Given this list of marker genes IFIH1, DUSP16, GBP7, VOPP1, ATP8B2, NBDY, IST1, FRMD4A, SGK3, COX15, KRTAP21-1, SDC4, PRKD3, AKT2, KEAP1, HMBOX1, KLRD1, CGAS (cyclic GMP-AMP synthase), TMPO, RPS11, RIPK2, STING1, MGAT4A, ANXA1, ITGA4, C8orf33, CLASP2, N4BP1 (NEDD4 binding protein 1), SREBF2, PROS1, IGF2R, STYX (NCBI Gene Id 730432), ANKIB1, GOLGA3, C6orf15, CCDC86, RPL34, ZC3H7A, PPP2R2A, LHX2, HOXD4, SH2D4A, MARF1, PPM1K, ZNF263, CD40, KATNA1, FUNDC1, EDNRB, RCAN1, CTXN3, DENND6B, SAP30, FANCC, SLC4A7, SETDB2, KCNN4, NUP153, AFF1, LUC7L3, ARHGAP26, FNDC3B, PEX5, CD83, NONO, NIBAN1, PDGFC, TSTD1, ANXA7, GCHFR, RAMP1, PGGT1B, MTMR7, CXCL11 (NCBI Gene Id 6373), BCAS3, WDR43, GPR84, F3, SLC39A14, SPSB1, H2AZ1, YWHAZ, IGFBP4, NSRP1, FYN, MAP2K4, BATF2 (NCBI Gene Id 116071), ALDH1L1, OAS2, RPL37A, TTYH1, ZYX, GLS, MAN2A1, STX12, SHOX2, LRCH1, SLFN13, PARP9, SEMA4C, LDLR, STX6, BBX (NCBI Gene Id 56987), RANBP2, BRIP1 (BRCA1 interacting helicase 1), CAAP1, ETNK1, TOMM70, SELENOP, TNFSF4, NRBF2, TRA2A, SERTAD3, MTMR11, HINT3, SPMIP3, RIOX2, FEM1C, GLUD1, SPIN4 (NCBI Gene Id 139886), THOC6, SAV1, GDA, ACSL5, PDE4B, PLOD2, ASAP3, PGM3, YTHDF1, PPIP5K2, NSD3, RPS9, CLTA (NCBI Gene Id 63271), CENPV, IL13RA1, DRAM1, EIF4G3, RPS14, NFKBIZ, MAP3K20, RBBP8, TPT1, MYO1A, USP12, PIP4K2A, FAM241A, PIM1, HLX, DCP2, SPRED1, CCDC6, CASP4, RPL38, MACROH2A1, CLIC4, PPP2R5A, PEBP4, STIP1, STAT3, SNX10, TASL, ETFB, TFAP2D, RAD54L, IQSEC2, CCNL1, MAPK1IP1L, RBMS1, KAT6A, BLTP1, IKZF1, TMTC4, C1QB, SPMIP7, PINK1, MSRA, ARID4A, CA2, SYNE3, CENPJ, RBMXL1 (NCBI Gene Id 494115), FAR1, MACIR, BFAR, CD69, CUTC, VCAN, HIPK2, CPEB4, SECTM1, ATP6V0E2, RPS10, DHRSX, RFNG, MAPKBP1, ASAH2, REEP3, SEC24B, PRXL2A, IL15RA, here is a description of the gene set: species: Homo sapiens from publication Covens K, Verbinnen B, Geukens N, Meyts I, Schuit F, Van Lommel L, Jacquemin M, Bossuyt X (PMID 23613519) Human Gene Set: GSE42724_NAIVE_VS_MEMORY_BCELL_DN Genes down-regulated in B lymphocytes: naïve versus memory. The recent discovery of the human B1 cells, identified by the expression of CD20, CD27 and CD43 in absence of expression of CD70 and CD69 has been subject of debate. Some studies have raised the possibility that these cells are B cells differentiating towards the plasmablast and plasma cell stage rather than being the human counterpart of murine B1 cells. No further in depth studies have been performed. Therefore, a functional comparison was made between, the proposed B1 cells and plasmablasts. We observed that for several functional characteristics (distribution of isotypes of spontaneously producted antibodies, production of antigen-specific antibodies after vaccination with both T-cell dependent as well as T-cell independent antigen, the proposed B1 cells behaved similar to plasmablasts. In addition, we were able to differentiate the proposed B1 cells in vitro, indicating that they are not from a distinct lineage as the murine B1 cells. Gene expression analysis revealed that these cells cluster between memory B cells and plasmablasts, contradicting them being the genuine human counterpart of murine B1 cells, rather revealing a preplasmablast phenotype.